The following is a description of a gene set: from publication Cui A, Huang T, Li S, Ma A, Pérez JL, Sander C, Keskin DB, Wu CJ, Fraenkel E, Hacohen N (PMID 38057668) Genes positively differentially expressed in cell type: cDC2 (conventional dendritic cell type 2) upon treatment with cytokine: IL-4 in mouse lymph nodes in vivo. studied in species Mus musculus Cytokines mediate cell-cell communication in the immune system and represent important therapeutic targets. A myriad of studies have highlighted their central role in immune function, yet we lack a global view of the cellular responses of each immune cell type to each cytokine. To address this gap, the authors created the Immune Dictionary, a compendium of single-cell transcriptomic profiles of more than 17 immune cell types in response to each of 86 cytokines (>1,400 cytokine-cell type combinations) in mouse lymph nodes in vivo. A cytokine-centric view of the dictionary revealed that most cytokines induce highly cell-type-specific responses. For example, the inflammatory cytokine interleukin-1β induces distinct gene programmes in almost every cell type. A cell-type-centric view of the dictionary identified more than 66 cytokine-driven cellular polarization states across immune cell types, including previously uncharacterized states such as an interleukin-18-induced polyfunctional natural killer cell state. Mouse Gene Set: CUI_CDC2_IL4_RESPONSE_UP, and this is the list of marker genes: Dnajb11, Denr, Kynu, Set, Ccl17, Hsp90ab1, Hnrnpa3, Tuba4a, Lsm7, Cyp51, Vrk1, Atp5f1b, Ppia, Cct3, Ddx39a, Uchl3, Pfn1, Cct8, Apex1, Snrpa1, Pno1, Eif4g1, Pdia6, Selenok, Ece1, Matk, Dnajc19, Anp32b, Tuba1b, Slc39a7, Pdcd1lg2, Wdfy4, Sarnp, Srsf2, Glrx, Sdf2l1, Atp5pb, Ndufa12, Atp5mf, Mat2a, Syngr2, Prkcd, Dad1, Ran, Magt1, Dok2, Hmgb1, Erh, Flt1 (NCBI Gene Id 14254), Gfra2, Cycs, Aco2, Tnip3, Arhgdia, Mgl2, Vps11, Atp5mk, Nucks1, Tmsb10, Xbp1, Batf3, Mif, Stip1, Cyb5r3, Eif5a, Dse, Psma3 (NCBI Gene Id 19167), Ppp1r14b, Hebp1, Hspd1 (NCBI Gene Id 15510), Sdc4, Tarm1, Hipk2, Hfe, Hnrnpr, Syncrip, Opa3, Fbl, Crip1, Atp5mc1, Necap2, Naa10, Comtd1, Cdc34, Nars1 (NCBI Gene Id 98111), Nudcd2, Rrp9, Ldha, Creld2, Cdh1, Cfl1, Crtc2, Hspa4, Eprs1, Ranbp1, Snx2, Ier3ip1, Calr, Cox6b1, Hspa9, Efhd2, Cltc, Rab3il1, Phb2, Alyref, Nme1, Gnl3, Slc29a3, Hnrnpk, Atp5mc3, Niban2, Mdh2, Pa2g4, C1qbp, Srsf10, Psmb7, Gar1, Prmt1, Pecam1 (platelet/endothelial cell adhesion molecule 1), Mrps5, Cox5b, Olfm1, Il4i1, Hyou1, Cd9, Tns1, Ybx3, Gorasp2, Aqp3, Nrp2, Lap3, Commd3, Gcsh, Pgk1, Eif4a1, Uchl5, Septin3, Lman2, Hsp90aa1, Pdia3, Mrpl10, Ctsz, Dynll1, Vdac3, Sec61b, Mrps15, Anp32e, Gsn, Tmem258, Micos10, Ndufc1, Atp5me, Ndufa1, Ndufa5, Chchd1, Hsp90b1, Psme3, Sfxn1, Ostc, Eif2b2, Polr1a, Plbd1, Casp6, Ak2, Adam8, Vapa, Rpn1, Chfr, Fmc1, Gfm1, Srm, Uqcr10, Selenos, Srsf9, Sdhb, Hspa5, Rrp1, Frmd4b, Wiz, Ybx1, Ruvbl1, Derl1, Foxn3, Fabp5, Pfkp, Ndufb7, Timm8a1, Mybbp1a, Uqcr11, Ncl, Tbc1d16, Pdia4, Ptges3, Atp5pf (ATP synthase peripheral stalk subunit F6), Sec61g, Gtpbp4, Hnrnpf, Mrpl12